Given this list of marker genes MRPL40, RCOR2, HMGA1, FGF6, GPM6B, MTHFD1, TESK2, FOXO3, EWSR1, RSPO2, CA14, AMPD2, DCTPP1, MNT, OSR1, KCNQ5, HOXB7, ELAVL3, METAP1D, COL2A1, LRP8, SATB2, SIGMAR1, POLR1G, UBXN10, U2AF2, PRR7, TRMT2A, CAD, KANSL1L, CHRM1, DAZAP1, HSPBAP1, MID1IP1, ATAD3B, KMT2A, CRMP1, IPO7, TAFA4, UBR5, MON1A, POGK, IQGAP2, PTGES2, CTIF, OPRD1, MIA2, SMC3, PPRC1, CEBPA, NRAS, TIMM10, BHLHA15, HOXA3, DNAJB5, POU3F2, HOXB5, SFXN2, RHEBL1, CNNM1, HHIP, RAI14, APOA5, ARL3, SDC1, ATAD3A, PTMA, NPM1, FLT3, RPS19, LZTS2, IPO13, ACY1, SLC25A32, EFNB1, PDIA2, KICS2, IVNS1ABP, SLC6A15, ASXL1, DIABLO, NTN3, ETV1, USP15 (NCBI Gene Id 9958), NCL, C2CD4A, RPS6KA5, KRTCAP2, NOL4L, BCAS3, REXO2, GADD45G, KCMF1, GPC3, CCDC191, ABCA1, TOP1, ADAMTS19, HSPA9, CDC14A, MAP7, SYNCRIP, ODC1, TRIM46, EPB41, BEND4, CLN3, NDUFS1, MAT2A, SMAD2, PER1, NUDC, SERBP1, ATF7IP, SNCAIP, MANF, NOP56, SLC43A1, RAMP2, ESRP2, PA2G4, CLUH, PRDX4, DYM, QTRT1, TIMM9, KLHL28, SNX5, GCSH, NRIP3, UBE2B, PRMT1 (protein arginine methyltransferase 1), MYCL, QTRT2, GJA1, GIT1, MGME1, TCOF1, EEF1B2, LYAR, ZBTB49 (zinc finger and BTB domain containing 49), HOXC11, ZC3H10, PPARGC1B, PRPS1, ARMC6, MPP3, BMP4, CSDE1, LAP3, CBX5, ILF3-DT, DERL3, ZNF565, RAB3IL1, STMN1, STXBP2, PITX3, AGO2, HNRNPH3, HNRNPDL, RFX4, RORC, KCTD15, FOXJ3, PTGR3, SLC17A9, TRIB1, PABPC1, TCERG1, USP34, IGSF22, KIAA0586, ESRRA, KCNH4, FGF14, PAICS, PUS1, TMEM108, RTN4RL2, TFRC, CYP2D6, NEUROD1, PCDHA10, GPS1, SRP72, SLC12A5, SLC49A4, DCAF11, PPAT, CSK, FKBP10, FKBP11, SYT3, SCRT2, TFAP4, ILF3, SUGP2, UBIAD1, RANBP1, G6PC3, TOGARAM1, ZNF771, FOXD3, TET2, TUBA4A, HOXA11, RHBDD3, NR6A1, SUCLG2, CEBPA-DT, ENO3, CGREF1, EIF4E, ADAMTS17, HIRA, TMEM59L, L1CAM, PDIA4, MXD4, BOK, IGF2BP1, IFRD2, RFX5, ETV4, TGFB2, ZBTB10, PFN1, RUNX2, PSME3 (NCBI Gene Id 10197), YEATS2, P3H4, SLC1A7, CHD4, HNRNPA1, TIMM8A, DIAPH1, TUBA4B, KDM3A, UBA1 (ubiquitin like modifier activating enzyme 1), DCAF13, KCNN4, RCL1, DAZL, BCL7C, MEOX2, ATOH8, UBR4, IRF9, CAMKV, ATG5 (autophagy related 5), PPP1R9B, ZHX2, WIPI1, H3-3A, GPRC5C, LIN28A, here is a description of the gene set: studied in species Homo sapiens Genes having at least one occurrence of the motif NNACCACGTGGTNN in the regions spanning 4 kb centered on their transcription starting sites. This matches the MYC, MAX transcription factor binding site V$MYCMAX_01 (v7.4 TRANSFAC). Human Gene Set: MYCMAX_01